Given this list of marker genes EIF4ENIF1, CAV1, PCCB, TWNK, MEIOSIN, SOHLH2, SYCP2L, HMMR, HAX1 (NCBI Gene Id 10456), MRPS22 (NCBI Gene Id 64953), SPIDR, CENPE, WT1, TP63, SWI5, FMR1, MND1, H1-8, LHX8, BRCA2, CCDC185, ALOX12, FANCA, HARS2, NOBOX, KASH5, BLM, NBN, LMNA, MCM8, BMPR1A (NCBI Gene Id 8035), STAG3, STRA8, AMHR2, LGR4, MST1R, ERAL1, FIGLA, SIL1, DAZL, HROB, ATM, SHOC1, DIAPH2, XPNPEP2, AIRE, LARS2, ESR2, LAMC1, PSMC3IP, AR, XRCC4, ANTXR1 (ANTXR cell adhesion molecule 1), NUP107, ERCC6, ATG9A, NLRP11, GALT, GNAS, EIF2B5, ESR1, NANOS3, FSHR, HSD17B1, CYP19A1, SOX8, PCCA, KHDRBS1, C1orf146, CPEB1, SLX4, PPM1B, FANCI, RFWD3, CLPP, FANCL, ZP3, BMPR2 (bone morphogenetic protein receptor type 2), LIG4, TGFBR3, MLH1, ELAVL2 (NCBI Gene Id 1993), NR5A1, WDR62, NUP43, PGRMC1, RECQL4, HFM1, DCAF17, EIF2B2, AMH, SGO2 (shugoshin 2), BNC1, BMPR1B, EIF2B1, DMC1, MCM9, PRDM1, EIF2B4, MSH5, HSD17B4 (hydroxysteroid 17-beta dehydrogenase 4), MEIOB, CYP17A1, SALL4, ZAR1, FANCC, PREPL, FANCM (FA complementation group M), SYCE1, PMM2, HELQ, BMP15, GDF9, WRN (WRN RecQ like helicase), STAR, AARS2, POF1B, ATG7, MCMDC2, MSH4, NOTCH2, BMP6, FOXL2, C14orf39, POLG, XRCC2, PRORP, MGME1, RAD51, POLR2C, SOHLH1, SPATA33, COX10, POLR3H, RCBTB1, EXO1, here is a description of the gene set: species: Homo sapiens Human Gene Set: WP_PRIMARY_OVARIAN_INSUFFICIENCY Primary ovarian insufficiency